The following is a description of a gene set: studied in species Homo sapiens Human orthologs of genes up-regulated in zebra fish after knockdown of BMYB by morpholino. A major goal of cancer research has been to identify genes that contribute to cancer formation. The similar pathology between zebrafish and human tumors, as well as the past success of large-scale genetic screens in uncovering human disease genes, makes zebrafish an ideal system in which to find such new genes. Here, we show that a zebrafish forward genetic screen uncovered multiple cell proliferation mutants including one mutant, crash&burn (crb), that represents a loss-of-function mutation in bmyb, a transcriptional regulator and member of a putative proto-oncogene family. crb mutant embryos have defects in mitotic progression and spindle formation, and exhibit genome instability. Regulation of cyclin B levels by bmyb appears to be the mechanism of mitotic accumulation in crb. Carcinogenesis studies reveal increased cancer susceptibility in adult crb heterozygotes. Gene-expression signatures associated with loss of bmyb in zebrafish are also correlated with conserved signatures in human tumor samples, and down-regulation of the B-myb signature genes is associated with retention of p53 function. Our findings show that zebrafish screens can uncover cancer pathways, and demonstrate that loss of function of bmyb is associated with cancer. from publication Shepard JL, Amatruda JF, Stern HM, Subramanian A, Finkelstein D, Ziai J, Finley KR, Pfaff KL, Hersey C, Zhou Y, Barut B, Freedman M, Lee C, Spitsbergen J, Neuberg D, Weber G, Golub TR, Glickman JN, Kutok JL, Aster JC, Zon LI (PMID 16150706) Human Gene Set: SHEPARD_BMYB_MORPHOLINO_UP, and this is the list of marker genes: TRIM16, RPL10L, GLUD1, HFE, MPP1, EPPK1, RAB36, LYRM1, FST, PCK1, SETD7, CYP11A1, GYG1, SSB, RPAP3, HNF4A, SCARB1, SLC31A1, DNTTIP2, POLR1C, VAMP7, WWOX, RRP8, LY75, ATP1A1, DLGAP4, IGF2, PDC, PNPO, CAMK1G, TPD52L2, NELFA, METAP1, CRABP2, FABP1, ARRDC3, DNAJA3, AIF1L, TYW5, CPN1, ZNF330, NCAPD3, NUDT9, MMP2, FOXI1, NCLN, RAB3C, IFI30, EPDR1, ACER1, VDAC3, ZNF622, HM13, ABCC5, STIP1, USP36, KRT18, TP53, WNT11 (NCBI Gene Id 7481), SQSTM1, UPB1, GMPR (guanosine monophosphate reductase), ZNF598, MS4A4A, ZNG1A, CASP8, HNRNPD, SESN3, SNX27, DNAJB4, SPPL2B, HSPB1, AGFG1, CUBN, PAPOLB, UCK1, EXOG, GPC4, MBD2, FXR1, SASH1, LETM2, GATD3, PLD4, EFHD2, SLC16A6, PARP4, DYNLT5, C4A, CFAP298, RHBG (NCBI Gene Id 57127), PDE6C, ARL6IP5, FOXO3, PLAA, ZC3H3, BCO2, PSMF1, LMAN2, OSGEPL1, BGN, GNS, CRLS1, MRPL19, PTP4A2, CCNG1, BAX, KLC1, PLEKHB2, TMUB2, ARHGAP29, BNIP3L, PARP6, RDH10, SH3GLB2, DUS3L, FNTB, RIOX2, MBP, BRF1, PARP3, HSD3B1, PTGES2, ENKUR, DNAJC10, PSMD3, GCSH, CYP26B1, TEX264, HMGA1, NR6A1, SLC25A28, RPS27, RIOK3, TPPP3, ATP6V1C2, SLX9, MB21D2, BMP2, CPNE3, NAPEPLD, RBM25, LAMP2, HSBP1, HPGD, TYW3, HTRA2, OLA1, VRK2, MRPL49, PRC1, SRSF4, ANXA2, WDR43, SOCS3, PSME1, MTRES1, MRPS18B, B2M (beta-2-microglobulin), MPPED2, KRT2, FBXO32 (NCBI Gene Id 114907), PTPRN, CIC, AIMP2, CNDP2, QKI, OSBPL10, S100A8, HSPA2, PTP4A3, DOHH, TP53INP1, DNAJA2, ABAT, TBX6, HSP90AA1, TEX9, EIF4E, MSI1, TMPO, PHLDA2, PGP, GNAI3, AK3, SND1, MDM2, TIMP2, SIRT1, TRIM47 (tripartite motif containing 47), ITFG2 (NCBI Gene Id 55846), FOXK2, MRM1, CFAP210, ARG1, CCNG2, SDF2L1, ZNRF2, RPP14, FOS, STARD3, RASL11B, PRDX1, ALG6, MTDH, SIAE, NSUN5, REXO2, RNF144B, PGAM1, ITM2B, NENF